Given this list of marker genes PPP3CA, PPARG, MIR34B, IL1A, F2R, MIR16-1, MIR199A1, EVA1A, MIR17, AGER, UMOD, TGFB1, MIR34A, MIR195, ROCK1, HIF1A, FKRP, RUNX1, FAM114A1, MIR214, ROCK2 (NCBI Gene Id 9475), MIR199B, C6orf89, MIR34C, MIR15B, TIMP1, here is a description of the gene set: The series of events leading to growth of connective tissue when loss of tissues that are incapable of regeneration occurs, or when fibrinous exudate cannot be adequately cleared. species: Homo sapiens Human Gene Set: GOBP_CONNECTIVE_TISSUE_REPLACEMENT